Given this list of marker genes Vegfa, Nrp1 (NCBI Gene Id 270112), Tgfbr1, Rxra, Pdgfrb, Fgf2, Ace, here is a description of the gene set: Blood vessel formation in the heart when new vessels emerge from the proliferation of pre-existing blood vessels. studied in species Mus musculus Mouse Gene Set: GOBP_ANGIOGENESIS_INVOLVED_IN_CORONARY_VASCULAR_MORPHOGENESIS